Given this list of marker genes Mapk6, Septin5, Septin10, Septin8, Mapkapk5 (NCBI Gene Id 17165), Septin9, Septin3, Septin14, Septin6, Septin1, Septin4, Septin7, Septin11, Septin2, Septin12, here is a description of the gene set: The part of the cytoskeleton (the internal framework of a cell) composed of septins and associated proteins. Includes septin cytoskeleton-associated complexes. species: Mus musculus Mouse Gene Set: GOCC_SEPTIN_CYTOSKELETON